Given this list of marker genes Gcnt3, B3gnt8, Galnt15, A4gnt, Chst4, C1galt1, Galnt9, Galnt14, St3gal3, B4galt6, B3gnt9, St3gal2, Muc15, Muc5b, Muc20, Muc17, Muc13, B3gntl1, Galnt12, B3gnt6, Galnt1, B3gnt3, Muc1, St6galnac2, Galnt4, Galntl5, St6galnac4, St6galnac3, St3gal4, Gcnt7 (glucosaminyl (N-acetyl) transferase family member 7), here is a description of the gene set: species: Mus musculus This event has been computationally inferred from an event that has been demonstrated in another species.<p>The inference is based on the homology mapping from PANTHER. Briefly, reactions for which all involved PhysicalEntities (in input, output and catalyst) have a mapped orthologue/paralogue (for complexes at least 75% of components must have a mapping) are inferred to the other species. part of: O-linked glycosylation electronically inferred by orthology from the curated human pathway Reactome Pathway: O-linked glycosylation of mucins